Given this list of marker genes PTPN7 (NCBI Gene Id 5778), LRRK2, RGS2, BLOC1S2, PTPN4, ALG2, SYT6, GNG11, DSG1, SNX18, RASAL3, ALG5, ESYT2, CFP, BORCS5, GNG5, SPPL2C, JAK1, RACGAP1, GNB1 (G protein subunit beta 1), SYAP1, ANK1, AJAP1, GNA11, GNG3, PPP3CA, MIEN1, GNG13, GNG5B, SLC4A1, LILRB4, GNAT1, FRMD6, BORCS8, ACP1, HTRA2, GNG14, STAC2, NTSR1, BLOC1S1, KRAS, IKBKB, QTRT1, JAK3, GNA12, RPS28, SHROOM4, HCK, NPHS2, CYLD, MAP2K2, DNAJA1, RASGRP4, AP2S1, GNAS, JUP, MTSS2, GNB4 (NCBI Gene Id 59345), CHUK, GNA14, RPS26, DTNA, ATP2C2, ALG13, CARMIL2, ESYT3, G6PD, GM2A, EPM2A, SPTA1, SAMD12, GNAL, CHMP7, GNG8, TH, DIABLO, KCNAB1, GNB3, TRAF2, NLRP10, DLG1, PTEN, CDH1, LITAF, SNX5 (NCBI Gene Id 27131), FERMT2, KXD1, CHMP4BP1, GNG12 (G protein subunit gamma 12), AP2A1, S100A6, SPPL2A, TRADD, LYN (NCBI Gene Id 4067), AKAP5, PTPN22, C2CD2L (NCBI Gene Id 9854), GNG4, CHMP4A, RASA3, CYTH1, RAB5A, RAB21 (RAB21, member RAS oncogene family), PKP4, FADD, THADA, CHMP4B, FES, EPM2AIP1, AP2A2, OSBPL2, CDK16, BECN1, AP2B1, ITPR3, KIT, LDLRAP1, GNAO1, GNGT1, GRK2, CDIP1, PRMT8, GPHN, SOCS3, RHOA (ras homolog family member A), SPPL3, DNAJA3, JAK2, GNAI2, KCNIP1, TRAF5, HID1, MYZAP, GNG10, GNAI1, RPS29 (ribosomal protein S29), PGM5, KCNAB2, TRAF3IP2, SPPL2B, GNAI3, BIRC2, GNG2 (G protein subunit gamma 2), TGM3, FRMD1, FER, RGS1, GNG7, GNB5, PTPN1, PPP1R9B (protein phosphatase 1 regulatory subunit 9B), MYD88, EPN3, EEF1A1 (NCBI Gene Id 96648), CHMP4C, FARP1, RNF31, MICALL1, EEF1A2, STAC3, SAMD10, GEM, TRAF3, AP4B1, PKD2, CNR2, GNAZ, DNAJB2, AP2M1, NCF1, QTRT2, TIRAP, RPL27, GNGT2, GNA13, TYK2, ASPSCR1, STAC, GNAT2, HM13 (NCBI Gene Id 92622), PTPN3 (NCBI Gene Id 5774), LITAFD, GNRH1, ALG1 (ALG1 chitobiosyldiphosphodolichol beta-mannosyltransferase), MYH10, GNB2, PTP4A1, BORCS6, RGS8, FKBP1A, MTSS1, IQGAP1, GNAT3, EFCAB7, SPTB, PLEKHA4, MCF2L, ALG14, GNAQ, CD2, MYH9, OTULINL, PTPRC, BORCS7, PALM, TRAF6, SNAPIN, GFAP, ALOX15 (NCBI Gene Id 246), GNA15, CACNB4, here is a description of the gene set: Human Gene Set: GOCC_CYTOPLASMIC_SIDE_OF_MEMBRANE species: Homo sapiens The side of a membrane that faces the cytoplasm.